Given this list of marker genes TCF7L2, LEF1, TCF7, CTNNB1, TCF7L1, MYC, here is a description of the gene set: Pathway Definition from KEGG: AvrA -> CTNNB1 -> TCF/LEF => MYC Salmonella AvrA to beta-catenin signaling pathway. Pathway ID: N01124. Pathway type: Pathogen. Pathway class: nt06505 WNT signaling. studied in species Homo sapiens Human Gene Set: KEGG_MEDICUS_PATHOGEN_SALMONELLA_AVRA_TO_BETA_CATENIN_SIGNALING_PATHWAY